The following is a description of a gene set: studied in species Mus musculus Mouse Gene Set: GOBP_EPIGENETIC_PROGRAMING_OF_MALE_PRONUCLEUS The global programming of epigenetic modifications in the male pronucleus of the newly fertilized zygote. The most major change in the paternal genome is DNA demethylation, which takes place before the first cell division., and this is the list of marker genes: Mettl23, Morc1, Stpg4, Tet3, Tet1